Given this list of marker genes Msr1, Lpl, Scarb1, Srebf2, Cd36, Ehd1, Apob, here is a description of the gene set: Any process that increases the rate or extent of cholesterol storage. Cholesterol storage is the accumulation and maintenance in cells or tissues of cholesterol, cholest-5-en-3 beta-ol, the principal sterol of vertebrates and the precursor of many steroids, including bile acids and steroid hormones. species: Mus musculus Mouse Gene Set: GOBP_POSITIVE_REGULATION_OF_CHOLESTEROL_STORAGE